The following is a description of a gene set: Vaginal neoplasm A tumor (abnormal growth of tissue) of the vagina. Human Gene Set: HP_VAGINAL_NEOPLASM species: Homo sapiens, and this is the list of marker genes: BUB3, BUB1B, COL4A6 (collagen type IV alpha 6 chain), BUB1, NAB2, COL4A5, TRIP13, CEP57, FH, STAT6